Given this list of marker genes SFMBT2, TENT5B, FSCN1, MACIR, AZIN2, CPA6, here is a description of the gene set: species: Mus musculus Human Gene Set: CHENG_TAF7L_TARGETS Genes down-regulated in testis tissues upon knockout of TAF7L. TFIID is a general transcription factor required for transcription of most protein-coding genes by RNA polymerase II. TAF7L is an X-linked germ cell-specific paralogue of TAF7, which is a generally expressed component of TFIID. Here, we report the generation of Taf7l mutant mice by homologous recombination in embryonic stem cells by using the Cre-loxP strategy. While spermatogenesis was completed in Taf7l(-/Y) mice, the weight of Taf7l(-/Y) testis decreased and the amount of sperm in the epididymides was sharply reduced. Mutant epididymal sperm exhibited abnormal morphology, including folded tails. Sperm motility was significantly reduced, and Taf7l(-/Y) males were fertile with reduced litter size. Microarray profiling revealed that the abundance of six gene transcripts (including Fscn1) in Taf7l(-/Y) testes decreased more than twofold. In particular, FSCN1 is an F-action-bundling protein and thus may be critical for normal sperm morphology and sperm motility. Although deficiency of Taf7l may be compensated in part by Taf7, Taf7l has apparently evolved new specialized functions in the gene-selective transcription in male germ cell differentiation. Our mouse studies suggest that mutations in the human TAF7L gene might be implicated in X-linked oligozoospermia in men. from publication Cheng Y, Buffone MG, Kouadio M, Goodheart M, Page DC, Gerton GL, Davidson I, Wang PJ (PMID 17242199)